Given this list of marker genes FBXO6, NCF1C, CFB, IFIT2, FCGR1A (Fc gamma receptor Ia), VAMP5, DLL1 (NCBI Gene Id 28514), SLC2A3, CDCP1, AMIGO2, NCF1B, PLEKHH1, TAP1, EXOC3L1, STAMBPL1, IRF1, APOL4 (NCBI Gene Id 80832), ALDH1A1, APOL3, KIAA0040, FFAR2 (free fatty acid receptor 2), ISG15, MUC1 (mucin 1, cell surface associated), PLSCR1, NEXN, STOM, GBP2, IFIT1, ARMH1, SDC3, TAP2, SLAMF7, STAT1, LHFPL2, IFI44 (interferon induced protein 44), CUL1, SUCNR1, FAM225A, PIM1, CACNA1A, MCEMP1, KIR3DX1, CARINH, CMPK2, SERPING1, XKR8, APOL2, KLHDC7B, C1QB, MYO7B, DTX3L, KREMEN1, IRF7, MT2A, LMNB1, DYSF, SLC12A8, SLAMF8, GBP3, FCGR1BP, GBP5, PFKP, ATF3, CD38, HAPLN3, ZBP1, CXCR2P1, CCND1, PRRT2, SIGLEC11, PSMB9, FCRL6, GBP4, ISG20, LAP3, LGALS3BP, LINC00189, C2, SAMD4A (sterile alpha motif domain containing 4A), APOL1, GAS6, ETV7, ANKRD22, AANAT, TNFSF10, MSR1, AIM2, SOCS3 (suppressor of cytokine signaling 3), AK4, CD40, WARS1, C1QC, PSME2P2, IFI44L, S100A8, IFI6, APOL6, SIGLEC16, SCO2, EPSTI1, IFITM1, PLAC8, STAB1, RHOBTB3, CD274, HLX, RNF213, C5orf58, GBP1P1, IDO1 (NCBI Gene Id 3620), SAMD9L, IFIT3, ADAM19, IFI35, PSME2, PLAAT4, BATF2, XAF1, PARP14, EGR3, BATF, ASAP2, NGFR, IGHEP2, CD7, UBE2L6, GBP1 (guanylate binding protein 1), PLCXD2, TMPRSS3, NLRC5, PARP9, CD226, SLC6A12, CCR1, PTK2, DDX60, CEACAM21, LDLR (NCBI Gene Id 3949), TYMP, FRMD3, EIF4E3, OAS3, NCF1, HERC5, TGM2, GSN-AS1, TIFA, SLC31A2, EID3, RUFY4, CIMAP1B, CXCL10, RASGRP3, ENPP2, USP18, SMTNL1, CASP7, L3MBTL4, TFEC, here is a description of the gene set: BACKGROUND: Vaccine development for influenza A/H5N1 is an important public health priority, but H5N1 vaccines are less immunogenic than seasonal influenza vaccines. Adjuvant System 03 (AS03) markedly enhances immune responses to H5N1 vaccine antigens, but the underlying molecular mechanisms are incompletely understood. OBJECTIVE: We compared the safety (primary endpoint), immunogenicity (secondary), gene expression (tertiary) and cytokine responses (exploratory) between AS03-adjuvanted and unadjuvanted inactivated split-virus H5N1 influenza vaccines. In a double-blinded clinical trial, we randomized twenty adults aged 18-49 to receive two doses of either AS03-adjuvanted (n = 10) or unadjuvanted (n = 10) H5N1 vaccine 28 days apart. We used a systems biology approach to characterize and correlate changes in serum cytokines, antibody titers, and gene expression levels in six immune cell types at 1, 3, 7, and 28 days after the first vaccination. RESULTS: Both vaccines were well-tolerated. Nine of 10 subjects in the adjuvanted group and 0/10 in the unadjuvanted group exhibited seroprotection (hemagglutination inhibition antibody titer > 1:40) at day 56. Within 24 hours of AS03-adjuvanted vaccination, increased serum levels of IL-6 and IP-10 were noted. Interferon signaling and antigen processing and presentation-related gene responses were induced in dendritic cells, monocytes, and neutrophils. Upregulation of MHC class II antigen presentation-related genes was seen in neutrophils. Three days after AS03-adjuvanted vaccine, upregulation of genes involved in cell cycle and division was detected in NK cells and correlated with serum levels of IP-10. Early upregulation of interferon signaling-related genes was also found to predict seroprotection 56 days after first vaccination. CONCLUSIONS: Using this cell-based systems approach, novel mechanisms of action for AS03-adjuvanted pandemic influenza vaccination were observed. TRIAL: ClinicalTrials.gov NCT01573312. species: Homo sapiens Genes up-regulated in dendritic cell 1d vs 0d in adults (18-49) after exposure to inactivated monovalent influenza A/Indonesia/05/2005 H5N1 split-virus vaccine, time point 1D, administered i.m. Human Gene Set: HOWARD_DENDRITIC_CELL_INACT_MONOV_INFLUENZA_A_INDONESIA_05_2005_H5N1_AGE_18_49YO_1DY_UP from publication Howard LM, Hoek KL, Goll JB, Samir P, Galassie A, Allos TM, Niu X, Gordy LE, Creech CB, Prasad N, Jensen TL, Hill H, Levy SE, Joyce S, Link AJ, Edwards KM (PMID 28099485)